Given this list of marker genes Prkd1, Dmpk (NCBI Gene Id 13400), Dmd, Rem1, Casq1, here is a description of the gene set: Any process that modulates the frequency, rate or extent of skeletal muscle contraction by changing the calcium ion signals that trigger contraction. Mouse Gene Set: GOBP_REGULATION_OF_SKELETAL_MUSCLE_CONTRACTION_BY_CALCIUM_ION_SIGNALING species: Mus musculus